Given this list of marker genes CCDC102A, NRARP, SPRYD7, CDC25A, PDP1, PRR36, POLR3G, METRNL, PLEKHA8, PIM2, GCSH, TARS1, POLR2B, ADH5, HAT1, ROMO1 (NCBI Gene Id 140823), FITM2, DCAF5, ARL5B, IGFBP5, PPP1R12A, GSS, KRTCAP2, LMF2, ELOVL5, NKAPD1, CDYL, CHM, EMID1 (EMI domain containing 1), JKAMP, OPLAH, LARS1, ATP8B4, NIFK, TEX9, PSMD2, GSC2, STMN1, KLHL4, PRPF6, HACD1, CYP20A1, WDR5, SLC35B4, CNPY4, NR2F6, ADAT2, RNF121, ATP6V1H, ARMCX3, PRMT5, PALD1, GEMIN4, USP20, GAS7, GRWD1, SLC7A1, TXNRD3, SDF2L1, CPTP, MTBP, IFITM10, SIRT3, ATP5MK, TUBA8, TAMALIN, PGGHG, RTTN, TMEM241, SPTLC1, YKT6, TIMM29, MRPL18, NRIP2, SLCO4A1, EGR2, COA7, ATPSCKMT, NRXN1, HARS1, PLPP2, MTREX, DPAGT1, HS3ST3B1, RABEPK, HMGA1, CEMIP2, EZH2, CTU1, SURF6, AP1S1, LIG1, CEP170B, PTPN9, PRODH, PRADC1, RGS16, YIF1A, TMEM109, EIF1AD, PIGF, GNB1, HSPA9, MESD, MVD, PKM, SNIP1, TBRG4, ENTPD7, RXRA, NCBP2, TDP2, NUP205, MBTPS2, CDK6, VAT1, RECQL, CASQ2, L3MBTL2 (L3MBTL histone methyl-lysine binding protein 2), GNPDA1, ICOS, BLOC1S4, POLDIP2, TTC5, STXBP5 (syntaxin binding protein 5), TP53BP1 (NCBI Gene Id 7158), EXOSC7, EMC7, UMPS, DDX20, ME2, ELP5, MAPK3, HAUS6, YIPF2, GSTCD, NDFIP1, CRLS1, NDUFC1, SLC35G1, NGDN (neuroguidin), GART, COPS5, DDX56, PSMC2, NDFIP2, APMAP, MSL3, TXK, ATP1B1, TMEM101 (NCBI Gene Id 84336), PANK1, PRR3, DTL, RAN, BYSL, CRTAP (cartilage associated protein), ZHX1, VMA21, UAP1L1, HSD17B12, ALDOA, MAGED2, GDPD5, DIPK1B, MAGT1 (magnesium transporter 1), SMAD1, ZWINT, SLC19A1, TPI1, TBC1D7, WDR18, ALG5, THYN1, PPP3CC, ST6GALNAC4, CDCA2 (cell division cycle associated 2), ENKD1, NLRC3, CABCOCO1, PLEKHA5, ZCCHC17, EME1, CRTAM, MAPRE2, CAMK2N1, PLRG1 (NCBI Gene Id 5356), CMSS1, LYRM4, LDAF1, RRP15 (ribosomal RNA processing 15 homolog), NDUFA9, CASTOR1, AIFM1, CDK5RAP3, ZWILCH, DGKI, SLC25A1, NCBP3, GMPR2, here is a description of the gene set: Genes up-regulated in comparison of NK cells treated with IL15 versus total splenocytes. studied in species Homo sapiens Murine NK cells were compared at rest and following 24 hours of IL-15 stimulation for their mRNA expression profiles on the Affymetrix MOE430_2 microarray platform. Additional comparators included resting bulk splenocytes. Human Gene Set: GSE7764_IL15_NK_CELL_24H_VS_SPLENOCYTE_UP from publication Fehniger TA, Cai SF, Cao X, Bredemeyer AJ, Presti RM, French AR, Ley TJ (PMID 17540585)